The following is a description of a gene set: Human Gene Set: GUTIERREZ_CHRONIC_LYMPHOCYTIC_LEUKEMIA_UP The tumoral clone of Waldenström's macroglobulinemia (WM) shows a wide morphological heterogeneity, which ranges from B lymphocytes (BL) to plasma cells (PC). By means of genome-wide expression profiling we have been able to identify genes exclusively deregulated in BL and PC from WM, but with a similar expression pattern in their corresponding cell counterparts from chronic lymphocytic leukemia (CLL) and multiple myeloma (MM), as well as normal individuals. The differentially expressed genes have important functions in B-cell differentiation and oncogenesis. Thus, two of the genes downregulated in WM-BL were IL4R, which plays a relevant role in CLL B-cell survival, and BACH2, which participates in the development of class-switched PC. Interestingly, one of the upregulated genes in WM-BL was IL6. A set of four genes was able to discriminate clonal BL from WM and CLL: LEF1 (WNT/beta-catenin pathway), MARCKS, ATXN1 and FMOD. We also found deregulation of genes involved in plasma cell differentiation such as PAX5, which was overexpressed in WM-PC, and IRF4 and BLIMP1, which were underexpressed. In addition, three of the target genes activated by PAX5 - CD79, BLNK and SYK - were upregulated in WM-PC. In summary, these results indicate that both PC and BL from WM are genetically different from the MM and CLL cell counterpart. from publication Gutiérrez NC, Ocio EM, de Las Rivas J, Maiso P, Delgado M, Fermiñán E, Arcos MJ, Sánchez ML, Hernández JM, San Miguel JF (PMID 17252022) Genes exclusively up-regulated in B lymphocytes from CLL (chronic lymphocytic leukemia) patients but with a similiar expression pattern in the normal cells and in the cells from WM (Waldenstroem's macroblobulinemia) patients. studied in species Homo sapiens, and this is the list of marker genes: PLXNC1, CD1C, MS4A1, PRKACB, IQSEC1, ITGA4, SMAGP, CYBB, LPIN1, GLRX, P2RX5, JCHAIN